The following is a description of a gene set: Human Gene Set: GOBP_REGULATION_OF_CYTOSOLIC_CALCIUM_ION_CONCENTRATION Any process involved in the maintenance of an internal steady state of calcium ions within the cytosol of a cell or between the cytosol and its surroundings. studied in species Homo sapiens, and this is the list of marker genes: HCRTR1, P2RY1, F2, WNT5A, CACNB4, TRPC7, FZD9, CNR1, CALCA, HCRTR2, ATP2B2, GRM5, TRPC4, ADCY8, TRPC6 (NCBI Gene Id 7225), CALCB, TRPC5, CAV3, CACNB2, SLC8B1, GRID2IP, CAV1, CLN3, ASPH, PLN, CDH23, TSPOAP1, OSBPL2, ERC2, SLC8A2, CALB1, GPER1, MYH7B, ATP2B1, RYR2, WBP2NL, ATP2B3, TMEM64, SV2B, YWHAE, NPY (neuropeptide Y), CAV2, BOK, TUNAR, CALB2, TMEM178A, RYR1, TRPC3, SLC8A3, GRM1, ITPR1, SLC35G1, P2RX1, TRPC1, ATP2B4, CNGB1, HRC, ADORA1